Given this list of marker genes Slc5a1, Cldn2, Vil1, Cldn15, Ezr (NCBI Gene Id 97496), Pls1 (plastin 1 (I-isoform)), here is a description of the gene set: species: Mus musculus Mouse Gene Set: GOBP_INTESTINAL_HEXOSE_ABSORPTION Uptake of hexoses, notably D-glucose, fructose, and galactose, into the blood by absorption from the small intestine.